The following is a description of a gene set: Mouse Gene Set: GOBP_REGULATION_OF_PHOSPHORUS_METABOLIC_PROCESS studied in species Mus musculus Any process that modulates the frequency, rate or extent of the chemical reactions and pathways involving phosphorus or compounds containing phosphorus., and this is the list of marker genes: Hmga2, Prkdc, Zbtb7a, Pdcd4, Eno1b, Prnp, Slc8a3, Errfi1, Trib3, Wnt1, Cd4, Mmp9, Oprd1 (NCBI Gene Id 18386), Parp14, Gadd45a, Rbl1, Chrm5, Il11, Fnip1, Bmpr2, Map2k7, Cnot9, Apc, Wdr59, Phactr1, Tab2, Dusp7, Egf, Tspo, Prxl2c, Bmp4, Ppargc1a (NCBI Gene Id 320239), Hif1a, Il13, Snca, Fzd1, Qars1, Dmtn, Wdr24, Phlpp1, Zzef1, Il9r, Pin1rt1, Cav2, Iqgap3, Dynap, Dnm1l, Nos3, Atxn7, Snx9, Ifnb1, Drd4, Tom1l1 (NCBI Gene Id 97729), Ccl19-ps5, Kif14, Emp2, Dnajc19, Gnas, Flt4, Ezh2, Map2k4, Musk, Trim6, Eif2ak3, Ropn1l, Ercc6, Zfp418, Ptges3-ps, Inca1, Tcim, Ifng, Ntf3, Firrm, Enpp7, Rap2c, Abca3, Entpd1, Gfra2, Gab1 (growth factor receptor bound protein 2-associated protein 1), Hyal2, Ucn, Plaur, Cd74, Limk2, Stox1, Pard3, Adtrp, Ttbk1, Spry1, Fmr1 (NCBI Gene Id 207836), Mir26b, Ndufc2, Txn1, Irs1, Cntn1, Ptpn2, Ccnyl1, Fbln1, Cntf, Dusp10 (dual specificity phosphatase 10), Arl2, Cspg4, Map3k7, Csf3, Pfkfb1, Ccdc159, Jak2, Edn1, Eng, Rgma, Ddr2, Ngf, Crh, Mir26a-2, Bscl2, Pdgfd, Dbndd2, Pik3ca, Htr2a, Acsl3, Ntrk2, Il21 (NCBI Gene Id 60505), Irgm1 (immunity-related GTPase family M member 1), Cep85, Jtb (NCBI Gene Id 23922), Apln, Bckdk, Bak1, Mas1, Nras, Epm2a, Rab38, Rabgef1, Tfrc, Ednrb, Cck, Inpp5j, Tada2a, Fgf8, Cd6, Mtmr1, Spdye4a, Cdh5, Drd1, Chordc1, Itgb1bp1, Tpd52l1, Csnk1d, Cdkn1a, Arf1, Limch1, Wnt3a, Vegfa (NCBI Gene Id 22339), Fbn1, Mre11a, Rap2b, Ptpn1, Hrc, Smg5, Zc3h12a, Map3k12, Tnfsf11 (NCBI Gene Id 21943), Spatc1l (spermatogenesis and centriole associated 1 like), Fgr, Map2k6, Ppp1r15b, Sema4d, Prkag2, Il3, Angpt1, Prkaa2, Trim27, Thbs4, Wnk4, Flt1, Dnaja3, Arl2bp, Sphk2, Tsacc, Cda, Mif, Inpp5f, Ppef2, Ptprz1, Fzd7, Wdfy2, Eef1a2, Ptk6, Lhcgr, Tgfa, Ppp5c, Raf1, Pycard, Spry2, Rgcc, Dynll1, Pdgfa, Brat1, Slc2a6, Prkcd, Cass4, Synpo2 (synaptopodin 2), Igbp1, Pink1, Acp4, Pip5kl1, Dusp19, Plxnb2, Lrrk2, Pdcd10, Nr2f2, Yes1, Icam1, Rasgrp1, Spink1, Mef2c, Gpnmb, Hipk3, Bend3, Lilrb4b, Psen2, Cdk2ap1, Mfsd2a, Dnajc30, Tlr1, Fem1a (fem 1 homolog a), Hnrnpu (heterogeneous nuclear ribonucleoprotein U), Traf4, Ereg, Mprip, Smg8, Ang, Dlg1, Nupr1, Nos1, Mstn, Hpn, Rasip1, Antkmt, Axin2, Adra2b, Adnp (activity-dependent neuroprotective protein), Il18, Il4, Pde5a, Ripk1, Jun, Akt1s1, Gas6, Hspb1, Map3k1, Arhgef5, Fgfr1, Nptn, Lrp6, Ppp1r15a, Hcls1, Cdc25b, Ptk2, Hrg, Pdk4, Spag9, Ptprt, Ccnd2, Parp9, Pou1f1, Eno1 (NCBI Gene Id 269605), Slc8a2, Rarres2, Rock2 (Rho-associated coiled-coil containing protein kinase 2), Cbfa2t3, Prkag1, Tenm1, Il15, Zbed3, Fbxo7, Camp, Dnajc3, Vangl2, Erbb2, Tnk2, Sh2d1b1, 2610042L04Rik, Fbp1, Fnip2, Fshr, Hnf1a, Dok7, Stat3, Lrrn3, Stap1, Pim1, Myh9, Chp2, Tspan9, Sik2, Tpk1, Pecam1 (platelet/endothelial cell adhesion molecule 1), Pik3r1, Prdx3, Trib1, Hnf4a, Pak1, Efna1, Wars1, Scarb1, Kirrel1, L1cam, Ccl19-ps4, Nck1, Csf1r, Cenpe, Trem2, Drd2, Kndc1, Fkbp8, Mmd, Uchl1, Arhgef2, Abi1, Prkd1, Cd244a (NCBI Gene Id 55952), Mtmr9, P2ry6, Abi3, Ncor1, Ehd4, Hsf1 (NCBI Gene Id 15499), Itgb3, Tnfaip3, Igf1, Cd24a, Gper1, Ntrk3, Pdk2, Ccn2, Rd3, Trim63, Ncl, Ppm1e, Card14, Ggnbp2, Rit2, Cdc37, Cav3, Agap2, Avpr1b, Mst1r, Bard1, Actn3, Thpo, Grk3, Cd300a, Kirrel2, Tnfrsf1a, Ighm, Rack1, Dusp3, Tmed2, Tnks1bp1, Prr5l, Blvra, Gpr39, Abca2, Csf2, Lime1, Gata1, Chga, Ip6k2, Sesn2, Nedd9, Pkia, Bdnf, Cdk5r2, Sirt1, Capn2, Cblc, Pdk1, Edn3, Nhlrc1, Ptpn11, Ubash3b, Trf, Gstp-ps, Cx3cr1, Lats1, Hgf, Srcin1, Rb1 (RB transcriptional corepressor 1), Dvl2, Cd109, Ocln, Faxdc2, Uvrag, Bmp7, Wnt9b, Men1, Dusp6, Stradb, Gdnf, Araf, Scp2, Dscam, Epha1, Odam, Pdgfb, Reg3b, Map3k5 (NCBI Gene Id 320994), Ptk2b, Fgd2, Crlf1, Ltf, Nf2 (neurofibromin 2), Adipoq, Il6ra, Kitl, Prlr, Hexim2, Ptprc, Il24, Impact (impact, RWD domain protein), Cdkn2a, Pbk, Tmem102, Ropn1, Ccl19-ps3, Fgf2, Camk1, Smad7, Bcar3, Mmd2, Mtmr4, Ppp4c, Shb, Pdk3, Enpp2, Sh2d1b2, Gpd1l, Bmp2, Chp1, Itpkb (inositol 1,4,5-trisphosphate 3-kinase B), Chrna7, Lmo4, Birc3, Niban1, Ccl19, Ptprb, Guca1b (NCBI Gene Id 224830), Hspa2, Thbs1, Arr3, Pth, Myog, Atp5if1, Cib1, Robo1, Mapk8ip1, Apoa1, Inhba, Bag1, Mcph1, Gadd45g, Ctnnd1, Ang6, Sdcbp (NCBI Gene Id 53378), Mir26a-1, Ttc36, Reg1, Gckr, Ralbp1, Il5, Smpd1, Angpt4, Ect2, Myocd, Ogt, Mtor, Ccdc88a, Stil, Nbn, Map4k2, Prkg1, Tcl1, Agrn (NCBI Gene Id 381587), Fgd4, Fabp3, Fis1, D1Pas1, Fas, Gsk3a, Tbx1, Spry4, Grem1, Mt3, Chek2, Kit, Cx3cl1, Cep43, Adra2a, Trpc6, Sfrp5, Ilk, Map3k10, Ksr1 (NCBI Gene Id 51965), Zgpat, Strada, Ppm1f, Plk1, Zfyve28, Adrb2, Cops8, Dab1, Cimap3, Mavs, Sphk1, Hipk2, Uri1, Stat2, Akap9, Senp2, Epha7, Prr5, Cab39, Zeb2, Prom2, Areg, Adipor2, Hdac3, Xrcc6, Ctdsp1, Ccny, Itga6, Prkar1a, Pid1, Tsg101, Rb1cc1, Tmem225, Socs5, Cnksr3, Dab2ip, Cd80, Erbb4, Acvr2a, Itga5, Heg1, Dtnbp1, Nsd1, Pth1r, Ptpn5, Stk4, Cadm4, Dvl3, Bcl2l1, Akap6, Parp1, Igfbp3, Cd44, Pibf1, Gstp2, Smyd3 (SET and MYND domain containing 3), Klhl31, Il31ra, Agt, Slc27a1, Mapk15, Rps3, Tab1, Dab2, Ikbkb, Irf1, Htr2c, Nherf1, Ddrgk1, Nox4, Braf, Map3k13, Cav1, Slfn1, Hmgb1, Isl1, Ptpn13, Bcl2, Rgs2, Rac1, Eif4g3, Gjc2, Map3k4, Hus1, Nron, Apoc2, Xbp1, Hdac2, Cacul1, Xdh, Taok3, Aldob, C1qtnf9, Sh3bp5, Reln, Ager, Ern1, Lrp4, Socs4, Trpt1, Kdm4d, Terf2ip, Tfap4, Ifnar1, Mapk8ip3, Trpc5, Abl1, Guca1a, Dstyk, Socs3, Gpd1 (NCBI Gene Id 14555), Avp, Gba1, Mvp, Fgf10, Lep, Rassf2, Rad17, Arrb2, Pin1, Nolc1, Gnb3, Adam9, Ptpn6, Garem1, Plec, Large1, Cd3e, Slc4a1, Hpx, Plpp3, Cdkn2c, Gck, Sox9, Ctf1, Cox11, Prkca, Myc, Htt, Gstp1, Tirap, Glmn, Sez6l, Ldb2, Chi3l1, Ptpro, Rock1, Ins1, Aplp2, Slc8a1 (solute carrier family 8 (sodium/calcium exchanger), member 1), Nup62, Fam20a, Ankle2, Tnfsf18, Hmgcr, Zbtb20, Inpp5k, Nrbf2, Ret, Pde4d, Paqr3, Park7, Gprc5a, Pxn, Akap5, Ang2, Slamf8, Mrnip, Grk1, Fn1, Trim65, Pik3cg (NCBI Gene Id 76039), Chrna3, Neurl1a, Ppp2r3c, Ar, Map2k2, Spred1, Ldb1, Tgfb1, F2, Sfrp1, Ripk2, Fgfr3, Psmd10, Hax1, Suz12, Pdgfrb, Ulk4, Apoc2l, Mtmr3, Hspa4, Atxn1 (ataxin 1), Akt2, Nrp1, Plcd1, Me1, Ibtk, Pak2, Map3k11, Pten, Ankrd54, Il9 (interleukin 9), Il22ra2, Tigar, Mapt, Tlr7, Slc25a12, Dgkq, Ednra, Atg14, Ptprh, Zfp622, Als2 (alsin Rho guanine nucleotide exchange factor), Crebl2, Tnfrsf4, Apoe, Bcl10, Ppp1r9b, Akt1, Mlxipl, Gpld1, Ccnb1, Cripto, Fbh1, Ep300, Ntsr1, Ncam1 (neural cell adhesion molecule 1), Epha4, Maged1, Dnajc10, Ptger4, Htr2b, Cdkn1b, Ntrk1, Bdkrb2, Nnt, Ptger3, Fndc1, Il7, Smpd3, Stk38, Sh3gl2, Gtpbp4, Nckap1l, Sptbn4, Npnt, Zfp91, Fcer1a, Lrp8, Gadd45b, Il6, Ralb, Rtraf, Nr1h4, Ppp2r5b, Tnf, Blm, Flcn, Pparg, Osbp, Pax6, Ccn1, Cldn3, Ctdspl, Trex1, Cadm1, Il34, Bst1, Pard6a, Pdgfra, Rspo1, Dusp22, Mapkap1, Anxa2, Mst1, Spn (NCBI Gene Id 20737), Fzd8, Iqgap1, Adcy8, Fzd5, Coro1c, Etaa1, Eif2ak4, Mapk1, Bmp6, Rapgef3, Cdon, Sema7a, Cdk12, Prkn, Eif4g1, Il6st, Tnik, Tlr6, Itgb1, Traf2, Lyn, Kctd20, Ppargc1b, Clcf1, Pebp1, Slc1a1 (NCBI Gene Id 319379), Fbxw7, Rgs14, Pkib, Rad50, Dock7, Ern2, Cdkn2b, Hbegf, Ccl19-ps6, Osm, Atpsckmt, Mcm7, Ang4, Prkag3, Traf6, Sfn, Ceacam1, Hdac6, Cdk5, Il2, Irak1, Nkx3-1, Tada3, Gprc5b (G protein-coupled receptor, family C, group 5, member B), Git1, Tmem132c, Ddit4, Traf3ip1, Itgb2 (integrin beta 2), Igtp, Itgb2l, Jmjd8, Tspyl2, Kdr, Gmppa, Cdk5rap1, Nlrp12, Dvl1, Prkce, Tek, Lox (NCBI Gene Id 16948), Nppa, Arnt, Ang5, Ripk3, Tnfrsf11a, Ctdsp2, Mapre3, Vtn, Dynapl1, Met, Srpx2, Smo, Adarb1, Plek, Flt3l, Hdac4, Src, Unc119, Fam20c, Tnfrsf18, Pkig, Higd1a, Gskip (NCBI Gene Id 66787), Pih1d1, Ptafr, Hsd11b1, Adora1, Daxx, Npm1, Ppp1r17, Fgf7, Hes5, Tgfb2, Clec7a, Il1b, Ppp1r42, Ptges3, Ppara (NCBI Gene Id 399624), Insm1, Rptor, Wnt5a, Peli2, Tmsb4x, Myadm (myeloid-associated differentiation marker), Gapdhs, Slc4a4, Sez6l2, Wwtr1, P2ry1, Lats2, Lepr, Csf1, Pkn1, Eef2k, Hgs (NCBI Gene Id 21921), Cldn19, Grb10, Pgk1, Fech, Trib2, Aida, Grk2, Phb2, Xrcc5, Fgf18, Bccip, Cdkn1c, Vegfc, Prkaca, Socs1, Rasa1, Nrg1, Ptgis, Cnot7, Nop53, Adar, Rap1a, Fgf4, Gpi1, Adcy10, Atf2, Ins2, Clspn, Mad2l2, Deptor, Ajuba, Cd40, Hsp90aa1, Rps23rg1 (ribosomal protein S23, retrogene 1), Hbb-bs, Tsc2, Axin1, Abi2, Mtch2, Irs2, Cdk2ap1rt, Nf1, Crkl, Adcyap1r1, Lif, Vldlr, Syk, Pcx, Adra2c, Nlrc5, Pla2g6, Cln3, Lilra5, Ier3, Tead1, Aif1, Zfp592, Phip, Tpx2, Map2k1, Aktip, Slc11a1, Ppp2r5d (protein phosphatase 2, regulatory subunit B', delta), Fiz1, Fzd4, Ptprj, Rbl2, Stk11, Prkch, Ccnd1, Ptpn22, Adcyap1, Bdkrb1, Prkcz, Gstp3, Akap11, Ldlr, Dusp1, Chmp6, Me2, Cryaa, Lck, Mydgf, Pik3r3, Ccl19-ps1, Apoc1, Rhoa, Cdk5rap3, Vegfb, Cactin, Rap2a, Prkaa1, Pdgfc, Hras, Tnfrsf14, App, Prox1, Sfrp2 (secreted frizzled-related protein 2), Tlr8, Dkk1, Notch2, Cartpt, Sez6, Kras, Tsc1, Gnaq, Cxcr4, Ndufs4, Map2k3, Celsr3, Lpcat1, Igbp1b, Insr, C3, Hhex, Lonp1, Kat2b, Cdkn2d, Amdhd2, Psrc1, Mlst8, Tm9sf5, Adam17, Nrxn1, Pik3r6, Slit2, Fgf1, Pfn2, P2rx7, Dnaja1, Rictor, Arrb1, Il12b, Cdk5r1, Flot1 (flotillin 1), Eif2ak1, Nek10, Egfr, Gbp4, Sirt2, Fgfr4, Prkrip1, Pdcl3, Bag4, Mob1b, Slco3a1, Card10, Cemip, Bank1, Il23a, Syap1, C9orf72, Rgn, Gfra1 (glial cell line derived neurotrophic factor family receptor alpha 1), Lrrk1, Sash1 (SAM and SH3 domain containing 1), Itln1, Sirt6, Nod2, Nprl2, Enpp1, Sod1, Lilrb4a, Ppia, S1pr2, Mob2, Casp3, Trp53, Ddx3x, Spred2, Lacc1, Esrrb, Tesk1, Hes1, Gsk3b, Epo, Clip3, Ube2k, Il22, Adora2b, Tlr4, Erp29, Tardbp, Vps25, Rapgef2, Wee2, Spata18, Irgm2, Acvr1, Camkk2, Mtmr2, Tlr9 (toll-like receptor 9), Aplnr, Midn, Thy1, Ccr7, Mlx, Bax, Fyn, Ppp2ca, Wnk3, Flt3, Adgrf5, Fer, Il12a, Fgf15, Ccnd3, Eif6, Dhx34, Vcp, Sqstm1, Idh1, Magi3, Mapk9, Rad51, Taf7, Macroh2a1, Ccl5, Mllt1, Efna5, Pik3r5, Psen1, Fabp4, Spdya, Irak3, Samsn1